Given this list of marker genes Tet2, Nipa1, Scn2b, Arl1, Mier3, Pik3r5, Rap1b, Nrp2, Itgb1, Psen2, Irf5, Esyt2, Eps8, Ktn1, Tle3, Aff1, Ascc3, Cd80, Fkbp1a (FK506 binding protein 1a), Ggta1, Tkt, Ncoa3, Samd1, Gabarap, Samhd1, Selplg, Pnp, Klf7, Dse, Gnai2, Rbm17, Ramac, Cd48, Ptms, Rb1, Cdkn1a, Cyfip1, Ptger4, Mdfic, Nfil3, Acsl5, Crem, Pde1b, Myl12a, Mefv, Slc27a3, Stat2, Palld, P2ry10, Gnb2, Snap23, Adcy6, Lmo2, Gnai3, Pfn1, Ccl22, Wars1, Pnrc1 (proline-rich nuclear receptor coactivator 1), Etnk1, Fnbp1l, Ndrg1, Lgals3, Gpx1, Zfp263, App, Psma3, Agps, Dek, Rap2a, Mvp, Fyco1, Clic1, Ccnd2, S100a6, Bach1, Mreg, Klf6, Gpbp1 (NCBI Gene Id 73274), Nudt9, Eif4a2, Rpain, Gclc, Adgrg6, Rac1, Serpina3g, Jaml, Ifi35 (NCBI Gene Id 70110), Cmtm6, Lima1, Iqgap1, Bzw1, Tmco3, Rasgrp1, Suv39h2, Ehd1, Srsf10, Trp53bp2, Psmd11, Ppdpf, Tmcc1, Mbd2, Cd274, Ccl17, Zbtb38, Nr4a3, St8sia4, Nfkb1, Clta, Cytip, Psap, Bcl2a1b, Anxa7, Dapk1, Csnk1d, Dcaf5, Adprh, Lpcat1, Serpinb6b, Galnt7, Ikzf4, Rere, Ctsz, Litaf, Sertad1, Diablo, Chd7, Traf5, Grk2, Kansl3, Fscn1, Atp6v1g1, Hepacam2, H1f10, Igsf9, Tcf4, Macroh2a1, Mapk1ip1l, Noct, Pnkd, Cr1l, Hsp90ab1, Cox17, Zmat5, Rexo2, Fchsd2, Sft2d2, Irs2, Ywhaq, Acadm, Tes, Fcgrt, Rai14, Nab1, Rab7, Tuba1b, Napsa, Pdcd1lg2, Riok3, Cyrib, Zfp398, Aldoa, Cish, Tmem109, Cd86, Peli1, Csf2rb, Zfand6 (zinc finger, AN1-type domain 6), Pkib, Wdr1, Ly75, Jak2, Pla2g15, Anxa4, Rel, Arhgdia, Tpm3, Socs1, Necap2, Tubb2b, Ywhag, Cd9, Sptbn1, Cnot6l, Sfr1, Tnfrsf11a, Slc7a5, Tbc1d4, Morf4l1, Slfn2, Smap2, Efhd2 (EF hand domain containing 2), Casp8, Ifi209, Coro2a, Atp11a, Basp1, Scly, Snx3, Rabgap1l, Fkbp1b, Oxct1, Acat2, Plgrkt, Tab2, Gnb4, Ywhae, Laptm4b (NCBI Gene Id 68111), Ahnak, Map3k1, Arid5a, Ralb, Plk2, Nckap1l, Hmgcr, Nampt, Foxn2, Ube2f, Il10ra, Anxa2, Tcp1, Eif3a, Zfp318, Rabep1, Tspan13, S100a10, Tmem70, Aldh1a2, Dtx3l, Pdlim5, Irgm2, Eloc, C1qbp, Dgka, Tnfrsf4, Gbp5, Vim, Slc25a38, Skap2, Snd1, Kif3b, Eif1a, Fmnl1, Eif2s1, Xbp1, Igtp, Klhl21, Plek2, Rnf115, Slc4a7, Syngr2, Snx8, Ptpn9, Mex3b, Ass1, Ptges3, Mcl1, Inpp5f, Cyb5a, Orai1, Cnn3, Fgl2, Stxbp6, Rara, Vopp1, Nuak2, Pim1, Rhoa, Pacsin2, Uqcr10, Anxa3, Ap1s2, Tmem65, Malt1, Ptpn1, Atp6v0a1, Diaph1, Tpm4, Atp11b, Ikzf1, Mtmr4, Nup88 (NCBI Gene Id 630141), Casp4, Cbl, Mapre2, Mob3a, Gyg1, Myadm, Ctsc, Cfl1, Mrpl13, Nrp1, Prkcd, Mylk, Yes1, Rab14 (RAB14, member RAS oncogene family), Gm266, Cd302, Sh3bgrl, Ywhah, Batf3, Tbca, Gnas, S100a11, Dnajc10, Glud1, Bcl2l11, Atrx, Prdm1, Mab21l3, Rab30, Ezr, Metrnl, Mfhas1, Jag1, Ncoa7, Kdm5c, Nap1l1, Glipr2, Snupn, Naaa, Ap2m1, Rhoc, Larp4, Rasa2, Sphk1, Jpt1, Znrf2, Cltc, Htr7, Vdr, Zbtb18, Bcl2a1a, Bcl7c, Olfm1, Relt, Mir155hg, Wipf1, Trip12, Bcl2a1d, Stk24 (serine/threonine kinase 24), Ywhaz, Spi1, Auh, Hspa8, Cdc42, Foxn3, Socs2, Zdhhc9, Tagln2, Cst3, Setd3, Plekha1, Csrp1, here is a description of the gene set: studied in species Mus musculus Cytokines mediate cell-cell communication in the immune system and represent important therapeutic targets. A myriad of studies have highlighted their central role in immune function, yet we lack a global view of the cellular responses of each immune cell type to each cytokine. To address this gap, the authors created the Immune Dictionary, a compendium of single-cell transcriptomic profiles of more than 17 immune cell types in response to each of 86 cytokines (>1,400 cytokine-cell type combinations) in mouse lymph nodes in vivo. A cytokine-centric view of the dictionary revealed that most cytokines induce highly cell-type-specific responses. For example, the inflammatory cytokine interleukin-1β induces distinct gene programmes in almost every cell type. A cell-type-centric view of the dictionary identified more than 66 cytokine-driven cellular polarization states across immune cell types, including previously uncharacterized states such as an interleukin-18-induced polyfunctional natural killer cell state. Mouse Gene Set: CUI_MIGDC_GM_CSF_RESPONSE_UP from publication Cui A, Huang T, Li S, Ma A, Pérez JL, Sander C, Keskin DB, Wu CJ, Fraenkel E, Hacohen N (PMID 38057668) Genes positively differentially expressed in cell type: MigDC (migratory dendritic cell) upon treatment with cytokine: GM-CSF in mouse lymph nodes in vivo.